Given this list of marker genes Fgf1, Fgf7, Fgfbp1, Fgf10, Fgf2, Fgfbp3, Fgf22, here is a description of the gene set: studied in species Mus musculus part of: FGFR2 ligand binding and activation This event has been computationally inferred from an event that has been demonstrated in another species.<p>The inference is based on the homology mapping from PANTHER. Briefly, reactions for which all involved PhysicalEntities (in input, output and catalyst) have a mapped orthologue/paralogue (for complexes at least 75% of components must have a mapping) are inferred to the other species. Reactome Pathway: FGFR2b ligand binding and activation electronically inferred by orthology from the curated human pathway